Given this list of marker genes Slc7a9, Bsg, Spn, Mag, Slc7a10 (solute carrier family 7 (cationic amino acid transporter, y+ system), member 10), Slc7a8, Ppia (peptidylprolyl isomerase A), Slc7a7, Cav1, Slc3a2, Slc16a8, Slc7a6, Atp1b3, Atp1b1, Slc16a3, Atp1b2, Ppil2, Itga3, here is a description of the gene set: studied in species Mus musculus This event has been computationally inferred from an event that has been demonstrated in another species.<p>The inference is based on the homology mapping from PANTHER. Briefly, reactions for which all involved PhysicalEntities (in input, output and catalyst) have a mapped orthologue/paralogue (for complexes at least 75% of components must have a mapping) are inferred to the other species. electronically inferred by orthology from the curated human pathway part of: Cell surface interactions at the vascular wall Reactome Pathway: Basigin interactions